Given this list of marker genes PDCL2, CFAP69, CFAP206, MEIG1, TTC12, CFAP58, SPEF2, DRC7, CFAP157, TPGS1, SPAG16, TTLL5, FSIP2 (fibrous sheath interacting protein 2), CCDC146, ARMC2, IQCG, CFAP43, CFAP47, BBOF1, LRRC46, PLA2G3, SPAG6, CFAP65 (NCBI Gene Id 255101), TTLL1, ZMYND12, DNAH1, CFAP97D1, NEURL1, CEP131, MNS1, TBC1D21, BBS2, CFAP44, UBE2B, here is a description of the gene set: Human Gene Set: GOBP_SPERM_AXONEME_ASSEMBLY studied in species Homo sapiens The assembly and organization of the sperm flagellar axoneme, the bundle of microtubules and associated proteins that forms the core of the eukaryotic sperm flagellum, and is responsible for movement.